The following is a description of a gene set: studied in species Mus musculus Mouse Gene Set: GOBP_ENDOCYTOSIS A vesicle-mediated transport process in which cells take up external materials or membrane constituents by the invagination of a part of the plasma membrane to form a new membrane-bounded vesicle., and this is the list of marker genes: Scarb1, Rin3, Sftpa1, Mfge8, Tmem175, Atad1, Snx17, Psg22, Itsn2, Syk (spleen tyrosine kinase), Mib1, Dgkd, Clu, Sh3gl1, Becn1, Creg1, Anxa2, Synrg, Pick1, Rin1, Rabgef1, Sele (NCBI Gene Id 20339), Sirpb1a, Myo1g, Lrp10, Itgal, Adrb2, Amph, Gsg1l, Apoc3, Marco, Magi2, Fnbp1, Hspa8, Snx3, Ighg2b, Smpd1, C9orf72, Ap2m1, Cryba1, Sod1, Hfe, Tbc1d24, Mapkapk2, Clta, Eea1, Epn3, Dock1, Synj2bp, Rala, Rhoj, Lepr, Lrp8, Carmil1, Hpca, Apln, Sh3gl3, Tbc1d5, Tmem108, Efnb2, Colec10, Sag, Hip1r, Cd209d, Abca1, Washc5, Apoa2, Fcho1, Kcnc3, Ighg1, Nme1, Rab27b, Pikfyve, Actb, Syt17, Ndp, Hspg2, Mesd, Lpar1, Slitrk1, Arhgap25, Srpx (sushi-repeat-containing protein), Anxa11, Cfp, Pacsin2, Fcgr1 (Fc receptor, IgG, high affinity I, NCBI Gene Id 99852), Pik3cb, Arpc3, Lrp11, Cd177, Atp8a1, Rab21, Neurl1b, Ptk2, Ap2a1, Plscr1, Park7, Colec11, Gata2, Myo1b (NCBI Gene Id 98177), Usp20, Aak1, Ppp3ca, Myo1h, Ighm, Fcnb, Hmmr, Myo15a, Clec7a, Plcg2, Stap1, Clint1, Drd2, Ins2, Pot1b, Ldlr, Lmbr1l (NCBI Gene Id 74775), Cd24a, Hras, Atg7, Lrp12, Siglecf, Tlr2, Ceacam2, Fgr, Trf, Arf1, Cav1, Nsf, P2ry6, Rab14, Pip4p2, C4bp, Neu3 (NCBI Gene Id 50877), Arl8b (NCBI Gene Id 69275), Eqtn, Nos2, Nod2, Tpcn2, Cd209b, Sort1, Ntf3, Unc119, Atp5f1b, Itgam, Cd36, Fcho2, Dbnl, Appl1, Elmo2, Myo5b, Apoe (NCBI Gene Id 11816), Josd1, Rubcn, Ap3d1, Itgb1, Snx33, Dnajc6, Dcx, AU040320 (expressed sequence AU040320), Kcnq2, Flot1, Caly, Ighe, Rab4b, Prkca, Src, Spon2, Ubqln2, Nckipsd, Apoc1, Syt11, Mrc1, Fchsd2, Pld2, Rabep2 (NCBI Gene Id 80753), Apela, Heatr5a, Scamp5, Ap3m2, Fpr-rs7, Wdr54, Vamp2, Xkr6, Bin2, Nckap1l, Rab5b (NCBI Gene Id 320645), Arfgap1, Necab2, Asgr1, Tor1a, Abca2, Ins1, Wasf1, Abr, Rnf220, Mx2, Lyst, Epn1, Tulp1, Ccl2, Pik3cg, Scamp1, Mbl1, Pear1, Ankfy1, Rab1a, Klrh1, Il4, Rab34, Fcer1g, Ahi1, Xkr7, Atg3, Mertk, Sh3glb2, Tgfbr2, Ap3b2, Ckap5, Ap3s2, Sncb, Rabgap1l, Inppl1, Cd9, Dennd1b, Cbl, Necap1, Pycard, Snx5, Rhou, Dkk1, Tfr2, Iqsec1, Wasf2, Btbd9, Colec12, Mkln1, Ehd4, Shh, Ophn1, Tub, Ptger3, Ticam2, P2rx7, Nr1h2, Gpr107, Cdc42, Aif1, Rufy1, Ankrd13a, Vav1 (vav 1 oncogene), Drd4, Chrna7, Eif2ak1, Tsc2, Rab11fip5, Drd3, Itga4, Fcgr4, Ehbp1, Ramp1, Tafa4, Clec4f, Ulk1, Lrsam1, Actg1, Rab11fip2, Rhov, Grk4, Ptpn1, Sirt2, Ppp3cb, Cap1, Ankrd13d, Arf6, Gria2, Myo6, Pik3c3, Ncdn, Ramp2, Atp9a (ATPase, class II, type 9A), Rab22a, Alms1, Pip5k1c, Timd6, Ghr, Cxcr1 (NCBI Gene Id 227288), Adipoq, Lrp1b, Atg5, Bin1, Dnm1l, Megf10, Snca, Calm3, Sorl1, Myo7a, Gulp1, Lrp4, Pla2g5, Apoc2l, Cntn2 (NCBI Gene Id 320300), Cdc42se2, Arap1, Hpse, Cdc42se1, Add1, Pacsin3, Slc2a4 (NCBI Gene Id 20528), Amn, Dnm3, Cd2ap, Dppa1, Csnk1g3, Susd4, Vamp4, Slc11a1, Slc9a3, Ralbp1, Nostrin, Gsn, Abca7, Cdh13 (NCBI Gene Id 74373), Ccr2, Prom2, Gas6, Syt4, Ncf4, Mrc2, Dock2, Plxnb2, Cd63, Clip3, Rock1, Ramp3, Snph, Dab2, Ppt1, Cd302, Abca13, Ackr3, Egfr, Cd209e, Trex1, Slc48a1, Rinl, Sdcbp, Mapk1, Lrrk2, Bcr, Pstpip1, Fcgr2b, Hgs, Itga2, Hamp2, Ehd1, Fpr-rs3 (formyl peptide receptor, related sequence 3), Mapk3 (NCBI Gene Id 26417), Egf, Myo7b, Arhgap21, Apoa1, Snx10, Il15, Grb2, Cbll1, Lrpap1 (NCBI Gene Id 97224), Aplp1, Ldlrad3, Jmjd6, Rara, Nr1h3, Wasl, Fkbp15, Zp3r, Cd14, Dnajc13, Insr, Snx12, Clec9a, Angpt1, Ralb, Rit2, Csnk1d, Cnn2, B2m, Dennd1a, Slamf1, Ush1g, Mtmr6, Lman2, Myo1d, Eef2k, Ifng, Prtn3, Rab20, Diaph1, Havcr1, Csnk1g2, Rnf216, Cd300lf, Myo5a (myosin VA), Sh3kbp1, Ceacam1, Siglec1, Csnk1g1, Pik3ca, Elmo3, Grn, Sirpa, Usp33, Opa1, Nlgn1, Trem2, Ankrd13b, Rin2, Coro1a, Tamalin, Ehd2, Myd88, Btbd8, Cd151, Cd300a, Gpc3, Cebpe (CCAAT/enhancer binding protein epsilon), Snx18, Atp6v1h, Lbp, Scrib, Appl2, Sncg, Smap1, Vtn, Lrp5, Ston2, Knl1, Timd4, Tyrobp, Epn2, Sftpd, Vldlr (very low density lipoprotein receptor), Arrb2, Lrrtm2, Lgals3, Ly75, Letmd1, Slc9b2, Csnk1e, Siglech, Myo5c, Abl2, Dgkq, Calcrl, Il15ra, Gapvd1, Mex3b, Abl1, Dennd1c, Prkn, Pros1, Sdc1, Hip1, Adm, Ank2, Arhgap12, Ccr7, Rap1a, Tusc2, Mctp1, Ap2a2, Kcnn4, Pten (phosphatase and tensin homolog), Tgm2, Ldlrap1, Dmbt1 (NCBI Gene Id 270001), Mapkapk3, Ccl19, Gas7 (growth arrest specific 7), Alox15, Pard3, Kcnq3, Ptprj, Dtnbp1, Cd44, Tyro3, App, Sfrp4, Serpine1, Hck, Cln3, Nrg1, Snap91, Ezr, Ptpn5, Reps1, Hmgb1, Fcgr3, Hnrnpk, Cttn, Vps28, Camk1d, Itgb3, Sh3bp4, Eps15, Pparg, Slc17a7, Scarb2, Stx1b, Cdk5, Calm1, Hamp, Mtmr9, Clcn3, Dlg4, Nedd4l, Grk2, Ager, Nedd4, Vegfa, Pacsin1, Capn2, Timd2, Il2rb, Itgb2, Plk2, Pld4, Entrep1, Mst1r, Rab7, Dnm1, Mff, Ccdc32, Arc, Lrrtm1, Arrb1, Tgfb1, Thbs1, Spry2, Grk3, Cav3, Rac1, Fcmr, Stx1a, Elane, Mdm2 (transformed mouse 3T3 cell double minute 2), Eps15l1 (epidermal growth factor receptor pathway substrate 15-like 1), Asgr2, Cxcr2 (NCBI Gene Id 12765), Reps2, Grem1, Btk (NCBI Gene Id 215271), Marchf2, Ap3m1, Tsg101, Ank3, Actn4, Rab39, Sh3bp1, Xkr8 (X-linked Kx blood group related 8), Heatr5b, Clcn2, Lrp2, Ube3a (ubiquitin protein ligase E3A), Sphk1, Necap2, Coro1c, Clcn5, Ap3s1, Icam5, Snx1, Dysf, Calr, Csk, Calm2, Synj1, Akap5, Bcl2l1 (NCBI Gene Id 12048), Myo19, Fmr1, Ano6, Mtmr2, Nlgn3, 4933434E20Rik, Esyt2, Timd5, Arr3, Ap2b1, Lmbrd1, Fpr-rs4, Lep, Rabep1, Bicd1, Synj2, Canx, Arfgap3, Ctbp1, Adgrb1, Rab17, Aplnr, Spg11, Cd209a, Trip10, Dll1, Myo18a, Syt7, Pcsk9, Unc13d, Ifitm3, Inpp5f, Lyar, Pla2r1, Nfix, Myo1a, Itsn1, Treml4, Tm9sf4, Ncf2, Arhgap27, Ppp3r1, Gak, Bltp1, Cblb, Ahsg, Siglece, Mbl2, Enthd1, Fnbp1l, Pecam1 (platelet/endothelial cell adhesion molecule 1), Tnk2, Scara5 (scavenger receptor class A, member 5), Rap1gap, Ston1, Msr1, Vac14, Atxn2, Ccl21a, Rab5a, Marchf3, Ppp3cc, Lilrb4a, Atp9b, Anxa3, Bmp2k, Cav2, Snx9, Lrp1, Myo1f, Myo1e, Rab31, Micall1, Mlc1, Cd81, Ehd3, Lrp6, Usp46, Dnm2, Scyl2 (SCY1-like 2 (S. cerevisiae)), Npc1, Prkcg (protein kinase C, gamma), Cyba, Cd22, Itgav, Rab5c, Lilrb4b, Tlr4, Cubn, Kif3a (kinesin family member 3A), Cltc, Sh3gl2, C2, Elmo1, Lyve1, Dpysl2, Tfrc, Picalm, Rapgef1, Ptprc, Rab4a, Myo1c, Vamp8, Myh9, Fpr-rs6, Epha3, H1f1, Cxadr, Rack1, Rab27a, Ap2s1, Bin3, Rhoq, F2rl1, Neurl3, Stab2, Numb, Tspan7, Anxa1, Fpr2, Apoc2, Wdr72, Syp, Il2rg, Itch, Rspo1, Ptx3 (NCBI Gene Id 99687), Il10ra, Hap1, Fcer2a, Wnt5a, Irf8, Cxcl16, Ache, Pik3c2a, Pllp, Napb, Steap2, Gria1, Cltb, Lipa, Sgip1, Rab11b, Cd47 (NCBI Gene Id 78539), C3, Tbc1d2b, Axl, Rnasek, Ncl, Xkr4, Wnt3a, Rab7b